The following is a description of a gene set: Mouse Gene Set: MIR_193A_3P_MIR_193B_3P Genes predicted to be targets of miRBase v22 microRNA mmu_miR_193a_3p, mmu_miR_193b_3p in miRDB v6.0 with MirTarget v4 prediction scores > 80 (high confidence targets). studied in species Mus musculus from publication Chen Y, Wang X (PMID 31504780), and this is the list of marker genes: Ino80d, Kcnj2, Tcf4, Kit, 4930503L19Rik, Pigh, Vipas39, Fat4, Vash1, Plau, Kdm7a, Erbb4, Gpr146, Sos2, Dmxl2, 6030498E09Rik, Tbl1xr1, Dcaf7, Adgrg5, Arel1, D430041D05Rik, Arhgef12, Hnrnpul2, Ing5, Spata7, Taok1, Plag1, Mmp19, Ap2m1, Rsf1, Cxxc4, Gmcl1, Otud6b, Caprin1, Igfbp5, Tmf1, Wdr95, Mapk10, Pla2g2d, Siah1a, Prkg2 (NCBI Gene Id 19092), Ets1, Gba2, Psg21, Heg1, Cnot6, Cadm1 (cell adhesion molecule 1), Zfp318, Lrrc8a, Kras, Ntpcr, Runx1t1, Fhdc1, 1110004F10Rik, Cbx7, 4930432M17Rik, Nav3, Brwd3, Hoxd13, Prr14l